Given this list of marker genes WASF1, ARHGEF26 (NCBI Gene Id 26084), CDKN1B, NEO1, CCNA2, DTNBP1, here is a description of the gene set: Human Gene Set: IWANAGA_E2F1_TARGETS_NOT_INDUCED_BY_SERUM from publication Iwanaga R, Komori H, Ishida S, Okamura N, Nakayama K, Nakayama KI, Ohtani K (PMID 16288221) Genes up-regulated in REF52 cells (embryonic fibroblast) by expression of E2F1 that were not induced at all at 16 hr after serum stimulation. The transcription factor E2F mediates cell cycle-dependent expression of genes important for cell proliferation in response to growth stimulation. To further understand the role of E2F, we utilized a sensitive subtraction method to explore new E2F1 targets, which are expressed at low levels and might have been unrecognized in previous studies. We identified 33 new E2F1-inducible genes, including checkpoint genes Claspin and Rad51ap1, and four genes with unknown function required for cell cycle progression. Moreover, we found three groups of E2F1-inducible genes that were not induced by growth stimulation. At least, two groups of genes were directly induced by E2F1, indicating that E2F1 can regulate expression of genes not induced during the cell cycle. One included Neogenin, WASF1 and SGEF genes, which may have a role in differentiation or development. The other was the cyclin-dependent kinase inhibitor p27(Kip1), which was involved in suppression of inappropriate cell cycle progression induced by deregulated E2F. E2F1-responsive regions of these genes were located more upstream than those of typical E2F targets and did not have typical E2F sites. These results indicate that there are groups of E2F1 targets, which are regulated in a distinct manner from that of typical E2F targets. studied in species Rattus norvegicus